Given this list of marker genes TDRD7, TDRD6, PLD6, TDRD1, TDRKH, TDRD5, here is a description of the gene set: species: Homo sapiens Human Gene Set: GOBP_OOCYTE_ANTERIOR_POSTERIOR_AXIS_SPECIFICATION Polarization of the oocyte along its anterior-posterior axis. An example of this is found in Drosophila melanogaster.